Given this list of marker genes SPINK5, UNC45A, MPI, PERCC1, FOXP3, SKIC2, ADAM17, DGAT1, ALG3, TBK1, SKIC3, WNT2B, PCSK1, IL2RA, STAT1, NLRC4, ALG9, LRBA, EPCAM, TOM1, DEF6, MYO5B, PMM2, CIITA, STX3, SLC9A3, SYK, here is a description of the gene set: Human Gene Set: HP_VILLOUS_ATROPHY The enteric villi are atrophic or absent. studied in species Homo sapiens Villous atrophy